Given this list of marker genes Gm6717, Pou2f3-rs1, Ralb (v-ral simian leukemia viral oncogene B), Cdh20, Steap3, Tfcp2l1, Tmem185b, Gm17946 (NCBI Gene Id 100416158), Gm15394, Gm8403, Zcchc2, Gm6679 (predicted gene 6679), Gm24553, Phlpp1, Ptpn4, Gm20302, Gm20753, Gm8321, Gm26509, Sctr, Serpinb2 (serine (or cysteine) peptidase inhibitor, clade B, member 2), Serpinb8, Gm5260, Gm8338, 1700121L03Rik, Gm3332, Gm22331, Gm15388, Gm8141, Slc35f5, D630008O14Rik, 3830432H09Rik, Cntnap5a, Gm10193, Mir6346, Marco, Gli2, Actr3 (ARP3 actin-related protein 3), Tsn, Serpinb3c, Gm26080, Nifk, Mir3473f, Gm3551, A530053M12Rik, Gm19927, Gm8392, D830032E09Rik, Serpinb12, Gm6693, Insig2 (insulin induced gene 2), Gm29455, Gm17752, Gm28282, Gm22438, Gm8004, Tmem177, Gm18181, Gm18448, B020011L13Rik, Dbi, Gm19086 (NCBI Gene Id 100418230), 9330185C12Rik, Gm18444, Gm8204, Gm25322, Serpinb5, Gm17973, Gm17634, Inhbb, Gm6028, Gm15389, Gm3508, Gm22159, Epb41l5, Dpp10, Gm15393, Ddx18, Cfap221, Gm7160, Relch, 3110009E18Rik, Gm8217, Rnf152, Clasp1, Pign, Gm29346, Gm17916, Gm3851, Serpinb13, Gm8084, Cdh19, Gm8173, Gm29454, Gm37053, Zfp658, Serpinb10, Gm8089, 2210011K15Rik, Gm25578, Gm28590, Gm18182, En1, Serpinb3d, Gm18875 (NCBI Gene Id 100417878), Serpinb11, Gm15390, Vps4b, Gm28363, Gm18801, Gm29658, Gm18552, Dsel, Gm24791, 2610027F03Rik, Gm17847, Serpinb3b, Gm24547, C1ql2, Bcl2, Serpinb3a, Cdh7, Gm23497, Gm28209, Htr5b, 1700012E03Rik, Celrr, Gm25771, Tmem37, Gm17777, Gm28929, Gpr39, Gm5702, Kdsr, Zfp813-ps, Gm20058, Ccdc93 (coiled-coil domain containing 93), Gm29012, 2900060B14Rik, Gm19965, Gm4854, Serpinb7, Gm28403, Tnfrsf11a, Gm18447, Gm7200, Gm28867, Gm8080, Gm29345, Gm24030, Gm7195, Gm6651, here is a description of the gene set: species: Mus musculus Mouse Gene Set: chr1E2